The following is a description of a gene set: Mannose type O-glycan biosynthesis, FKTN to LARGE. Pathway ID: N00699. Pathway type: Reference. Pathway class: nt06013 O-Glycan biosynthesis. species: Homo sapiens Pathway Definition from KEGG: G13092+CDP-Rib-ol -- FKTN >> FKRP >> TMEM5 >> >> LARGE1/2 -> G13099 Human Gene Set: KEGG_MEDICUS_REFERENCE_MANNOSE_TYPE_O_GLYCAN_BIOSYNTHESIS_FKTN_TO_LARGE, and this is the list of marker genes: LARGE2, RXYLT1, FKTN, FKRP, LARGE1, B4GAT1